The following is a description of a gene set: studied in species Homo sapiens Genes predicted to be targets of miRBase v22 microRNA hsa-miR-6499-3p in miRDB v6.0 with MirTarget v4 prediction scores > 80 (high confidence targets). from publication Chen Y, Wang X (PMID 31504780) Human Gene Set: MIR6499_3P, and this is the list of marker genes: TRIM48, JPH3, MAP4K3, NAV1, OSBPL3, MEX3C, RORA, ADGRG2, PMP2, E2F3, ZNF154, C14orf132, KLF10 (KLF transcription factor 10), AP2B1, KHDRBS1, GRID2, VWC2L, SCN1A, RAB35, VGLL4, ESR1, PDIA6, FUT9, ASXL1, FUT8, WASF1, DLG2, LYST, NRN1, SMAD9, PRKCI, NBPF20, ST3GAL5, PNMA5, ELMOD1, PDE4B, GATM, PLAA, EML5, WSCD2, NUDT9, ZBTB21, GMFB, INPP5A, TRAPPC10, PHGDH, CTTNBP2NL, CCDC144NL, GCSH, NBPF14, ELOVL6 (ELOVL fatty acid elongase 6), CDH13, TBP, ELL2, MAT2A, ULBP3, MAP3K20, DLL1, CSTF2, SLC12A6, ZNF480, MTR, XYLT1, MEIOC, ZDHHC17 (NCBI Gene Id 23390), EMILIN2, MDM4, C2orf15, MTSS1, DIXDC1, LIX1, PPIP5K1, GRINA, SGTB, API5, KIFAP3, ZBTB20, C2CD2, RRAGC, SCAF4, POU3F2, AJUBA, NBPF15, RPS3, CD160 (NCBI Gene Id 11126), NBPF8, SLC36A3, MAP3K11, RAB6C, CRP, HACE1, GUCY1A1, ZBTB18, NCOA3, ROBO2, TANC2, B3GNT4, WDR82, ARFGEF2 (ADP ribosylation factor guanine nucleotide exchange factor 2), NQO1, RAB21, GABRA3, ZFHX4, GPRASP3, NEXMIF, DENND4C, GSG1, GPR158, CAPN6, TBL1XR1, CHD1, LRRTM4, SVIP, PTPN4, USP33, HIPK3, SYDE2, CACNB2, UBE2Q1, SMIM15, EPB41L5, GRIN3B, SLC49A4, DAAM1, SSR1, MET, SMYD2